The following is a description of a gene set: Genes up-regulated in macrophages with IL10 knockout in response to 20 min treatment by: LPS versus LPS and IL10. Human Gene Set: GSE9509_LPS_VS_LPS_AND_IL10_STIM_IL10_KO_MACROPHAGE_20MIN_UP from publication El Kasmi KC, Smith AM, Williams L, Neale G, Panopoulos AD, Watowich SS, Häcker H, Foxwell BM, Murray PJ (PMID 18025162) IL-10 regulates anti-inflammatory signaling via the activation of STAT3, which in turn controls the induction of a gene expression program whose products execute inhibitory effects on pro-inflammatory mediator production. Here we show that IL-10 induces the expression of an ETS family transcriptional repressor, ETV3 and a helicase family co-repressor, SBNO2 (Strawberry notch homolog 2) in mouse and human macrophages. IL-10-mediated induction of ETV3 and SBNO2 expression was dependent upon both STAT3, and co-stimulus through the TLR pathway. We also observed that ETV3 expression was strongly induced by the STAT3 pathway induced by IL-10 but not STAT3 signaling activated by IL-6, which cannot activate the anti-inflammatory signaling pathway. ETV3 and SBNO2 specifically repressed NF-kB-mediated transcription and can physically interact. Collectively our data suggest that ETV3 and SBNO2 are components of the pathways that contribute to the downstream anti-inflammatory effects of IL-10. We compared expression profiles of macrophages isolated from IL-10 -/- mice. Macrophages were treated with either LPS or LPS plus IL-10. Treatment times were 10, 20 and 30 minutes. studied in species Homo sapiens, and this is the list of marker genes: IKZF2, ABCB1, SLC35F6 (NCBI Gene Id 54978), MECOM, PLSCR4, ANGPT1, EHD2, CD7, C3, EEF2, NPR3, NOTCH4, SYCP2, GCSAML, ADGRG6, PLXDC2 (NCBI Gene Id 84898), AKR1C2, PROS1, ZNF862, CNKSR1, IFITM3, RIN2, TMC6, RAB37, MALL, CNST, BIRC3, HOXB3, ITGA2B, PDZD2, FN3K, SESN3, MLLT3, SAV1, TTC7B, GFI1B, EHD3, SKAP1, SIRT4, NFKBIZ, FAM219B, KLKB1, FKBP9, CTDSPL, VPS8, ZNF768, ACRBP, DNAH10, CALN1, BACE2, PRKCH, HSD17B11, GMPR, HTR1F (NCBI Gene Id 3355), LTBR, PAX5, GLS2, CAMLG, BMAL2 (NCBI Gene Id 56938), ARMCX1, ATXN7L1, ACACB, SPTLC2, STARD9, ROBO4, DAPK1, RXRB, EPHB4, ADAM8, MCL1 (NCBI Gene Id 4170), MTG2, PLOD2, ARSD, LIMCH1, ARHGAP36, WWTR1, ARHGEF40, EFNB2, PRSS36, SLC8A3, GPR146, MAPRE3, CCDC87, LOXL1, STX17, ATP9A, ZNF521, IDNK, GALNS, TESPA1, GIPC2, CDC14B, NRIP1, PPP1R9A, DDN (NCBI Gene Id 23109), TBC1D25, KAZALD1, RAB13, TMEM64, ACOX2, LRP4, C1orf216, IGSF9, CRHBP (NCBI Gene Id 1393), IGSF10, RABGAP1, CAVIN1, ZNF692, JPH4, GBP4, FGD5, SOCS2, MYCT1, RAB27B, SMIM10L1, SLC49A4, RSAD2, ZNF282, TPTEP1, SMARCA2, ELOVL7, FOXO1, RBPMS, CFAP46, PKD2, ERG, FAM210B, CCN2 (NCBI Gene Id 1490, cellular communication network factor 2), ARHGAP22, ALDH1A1, IL12RB2, FAM117A, TAL1, LINC00899, COL5A1, ZNF385D, NFIA, LINC02981, MPL, STON2, GUCY1B1, KSR1, ZNF501, GP1BA, NMU, PBX1, HEMGN, ST6GAL2, C1RL, SNRK, GATAD1, ADAMTSL4, IP6K3, GAS1, NFATC2, TDRP, CHRM3, ATP7B, HMGA2, BCORL1, ABLIM1, PPFIBP1, FITM2, TRIM39, TMEM140, SAA3P, PRKG2, EPCIP-AS1, SNHG12, C1QL1, SPRY4, RNF150, IGKV4-1, CFH, STEAP1B, SLC35D2, VWA8-AS1, TAFA2, TSPAN6, RIPOR3, SMIM1, GLB1L, H2BC21, CIMIP4 (ciliary microtubule inner protein 4), SLC2A10, LPCAT2, PGAP4, RHOB, TNRC18, PEAR1, PNMA1, INHA, LRP6, DYNLT5, NEAT1